Given this list of marker genes CDC42, LGALS1, KITLG, BAX, CTSS, CRIP1, MRC1 (mannose receptor C-type 1), CCL15, PCNA, MCM5, LYZ, MFAP2, GNAI2, SERPINH1, ACTA2, CES1, EED, ARSA, AKIRIN2, CTSZ, APLP2, S100A10, SAT1, NFKBIA, SLC25A4, CD74, ZFAND5, C3, CD9, COL3A1, TANK, S100A13, CYFIP1, POSTN, CFD, NPTN, CLK1, GAS6, LAMA4, CCND2, TIMM22, COL5A2, ITM2B, ADIPOQ, GNB1, CA3, COL1A2, HBA2, AGR2, TUBB (NCBI Gene Id 95295), GJA1, ALAS2, ACTG1, IGFBP5, ANGPTL2, HNRNPA2B1, SERPINB6 (serpin family B member 6), SCG2, ANXA3, ADH5, TUBA1B, CNN3, TUBA1A, FMO1, EMP1, TYROBP, PMP22, UGDH, MCM3, CACYBP, LUM, CD34, S100A11, TUBB2A, PKD2, AP4S1, CXCL13, SERPINF1, LIMS1, CKS1B, SPARC, NFIB, CD53, S100A6, SEPTIN2, CADM1, DAB2, ACADL, RHOB, COL1A1, SKP1, SMAD1, COL6A3, CCNG1, COL15A1, CSRP1, EVL, LPL, C1QB, ENPP2 (ectonucleotide pyrophosphatase/phosphodiesterase 2), CD47, RBP1, IGFBP4, LAPTM5, ANXA2, ITGB1, CALM2, COL4A1, FBLN2, NID2, ACADM, DNAJA1, OGN, CRTAP, APOE, CTSE (cathepsin E), B2M, KRT19, SEPTIN7, LAPTM4A, CDKN1C, CDC6, DSTN, LCP1, ELN, CAPZA2, GSN, C1QA, LYL1, COL6A2, CLIC1, COL18A1, LMNA, SMC2, TMEM45A, CDO1, RBBP7, SS18, BZW1, DCN, ITM2A, C1QC (NCBI Gene Id 90369), MCM7, here is a description of the gene set: Human Gene Set: IGLESIAS_E2F_TARGETS_UP studied in species Mus musculus Genes up-regulated in pancreatic cells from mice with double knockout of E2F1 and E2F2 compared to wild type. from publication Iglesias A, Murga M, Laresgoiti U, Skoudy A, Bernales I, Fullaondo A, Moreno B, Lloreta J, Field SJ, Real FX, Zubiaga AM (PMID 15146237) E2F transcription factors are thought to be key regulators of cell growth control. Here we use mutant mouse strains to investigate the function of E2F1 and E2F2 in vivo. E2F1/E2F2 compound-mutant mice develop nonautoimmune insulin-deficient diabetes and exocrine pancreatic dysfunction characterized by endocrine and exocrine cell dysplasia, a reduction in the number and size of acini and islets, and their replacement by ductal structures and adipose tissue. Mutant pancreatic cells exhibit increased rates of DNA replication but also of apoptosis, resulting in severe pancreatic atrophy. The expression of genes involved in DNA replication and cell cycle control was upregulated in the E2F1/E2F2 compound-mutant pancreas, suggesting that their expression is repressed by E2F1/E2F2 activities and that the inappropriate cell cycle found in the mutant pancreas is likely the result of the deregulated expression of these genes. Interestingly, the expression of ductal cell and adipocyte differentiation marker genes was also upregulated, whereas expression of pancreatic cell marker genes were downregulated. These results suggest that E2F1/E2F2 activity negatively controls growth of mature pancreatic cells and is necessary for the maintenance of differentiated pancreatic phenotypes in the adult.